Given this list of marker genes Slc22a1, Adal, Nt5c2, Slc22a2, Slc22a3, here is a description of the gene set: part of: Drug ADME electronically inferred by orthology from the curated human pathway Reactome Pathway: Abacavir ADME studied in species Mus musculus This event has been computationally inferred from an event that has been demonstrated in another species.<p>The inference is based on the homology mapping from PANTHER. Briefly, reactions for which all involved PhysicalEntities (in input, output and catalyst) have a mapped orthologue/paralogue (for complexes at least 75% of components must have a mapping) are inferred to the other species.